Given this list of marker genes LIN28B, ELN, ERVW-1, CLOCK, LCP2, PLSCR1, GNE, RNF14, RSU1, COL2A1, SULT1C4, MED21, PACSIN2, EPB41, WDR55, MAP3K10, DDX42, FLRT2, ADRA1A, PTN, KATNAL2, AHDC1, LUM, SPATA31A7, KIF3C, ZEB1, SYT14, PRKCB, BVES, TEAD1, SPATA31A3, PDS5A, MAT2A, CACUL1, APBB2, VGLL3, FAM131B (family with sequence similarity 131 member B), SPATA31A5, SPATA31A1 (SPATA31 subfamily A member 1), SYNC, MBNL2, KIF20B, ARHGEF5, SPATA31A6, ADGRB2, LRRN2, AGO1 (NCBI Gene Id 26523), YWHAQ, PEG10, RORA, HOXB9, CCDC146, STRN4, here is a description of the gene set: Human Gene Set: MIR5586_3P Genes predicted to be targets of miRBase v22 microRNA hsa-miR-5586-3p in miRDB v6.0 with MirTarget v4 prediction scores > 80 (high confidence targets). species: Homo sapiens from publication Chen Y, Wang X (PMID 31504780)